The following is a description of a gene set: species: Homo sapiens Human Gene Set: GOBP_SINOATRIAL_NODE_DEVELOPMENT The process whose specific outcome is the progression of the sinoatrial (SA) node over time, from its formation to the mature structure. The SA node is part of the cardiac conduction system that controls the timing of heart muscle contraction. It relays electrical signals to the AV node., and this is the list of marker genes: GATA6, SHOX2, ISL1, BMP4, BVES, HCN4 (hyperpolarization activated cyclic nucleotide gated potassium channel 4), TBX18, TBX3, CACNA1G, TBX5, MESP1, GJB6